Given this list of marker genes Hoxa11, Prom1 (prominin 1), Il6ra, Sox8, Bmp4, Ednrb, Mef2c, Cflar, Dlg1, Maged1 (MAGE family member D1), Bcl2, Pdgfa, Abcc2, Ctns, Ahr, Foxj1, Yap1, Agtr1a, Osr1, Lzts2 (NCBI Gene Id 226154), Pdgfb, Pax8, Edn1, Hs3st3a1, Irx3, Irx1, Wnt4, Mtss1, Hoxb7, Aqp1, Cited1, Heyl, Acta2, Kif26b, Col4a3, Pdgfra, Fgf2, Wnt7b, Pax2, Dchs1, Six4, Egr1, Adipoq, Wnt11, Gpc3, Ilk, Sall1, Nog, Magi2, Tfap2a, Fgf1, Umod, Agtr1b, Tgfb1, Slc22a6, Adamts16, Fat4, Nid1, Pou3f3, Vangl2, Ptch1, Pdgfrb, Gpr4 (G protein-coupled receptor 4), Hoxd11, Sulf2, Timeless, Cd24a, Itga3, Sec61a1, Serpinb7, Ampd2, Dll1, Ptpro, Myc, Grem1, Tcf21, Notch3, Fgf8, Shh, Hs2st1, Dspp, Bmp7, Gata3, Pspn, Hes1, Cd44, Tek, Tmem59l, Basp1, Ctnnbip1, Enpep, Acat1, Gli3, Tfap2b, Comt, Sulf1, Fmn1, Foxd1, Hey1, Sox9, Nup133, Greb1l, Cfh, Nup107, Pgf, Nup85, Myo1e, Jag1, Mir216a, Iqgap1, Ctnnb1, Vegfa, Tacstd2, Bmp2 (bone morphogenetic protein 2), Hs3st3b1, Cd2ap, Actn4, Smo, Col4a4, Cited2, Ppp3ca, Irx2, Aqp11, Hc, Ednra, Foxc1, Calb1, Six2, Erbb4 (NCBI Gene Id 13869), Notch2, Asxl1, Lif, Wwtr1, Lamb2, Ext1, Commd5, Wnt2b, Ifng, Pbx1, Gdnf, Ctnnd1, Angpt1, Agtr2 (NCBI Gene Id 11609), Wt1, Notch1, Wnt1, Nphs1 (nephrosis 1, nephrin), Mpv17, Lgr4, Wnt6, Wnt9b, C3ar1, Nphs2, Nup160, Wnk4, Stat1, Klf15, Plce1, Smad4, Pdgfd, Foxc2, Mir216b, Pkd1 (polycystin 1, transient receptor potential channel interacting), Cd34, Klhl3, Angpt2, Agt, Lhx1, Pkd2, Podxl (NCBI Gene Id 27205), Itgb3, Ret, Six1, Lama5, Dchs2 (NCBI Gene Id 627094), Kirrel3, Hnf1b, Slc22a1, Hes5, Eya1, Npnt, Mir217, Gzf1 (NCBI Gene Id 74533, GDNF-inducible zinc finger protein 1), here is a description of the gene set: Mouse Gene Set: GOBP_NEPHRON_DEVELOPMENT The process whose specific outcome is the progression of the nephron over time, from its formation to the mature structure. A nephron is the functional unit of the kidney. studied in species Mus musculus